Given this list of marker genes Zfp735, Calcoco1, Zcchc18, Vps29, Dcp2, Card10, Ppp1r9b, Eif2s2, B3glct, Rbm41, Ap3m1, Foxn3, Zfp426, Lbp, Ago1, Myo6, 9530002B09Rik, Bmerb1, Mdh1b, Zfp616, Rb1, Tac4, Klhl7, Syt4, Zdhhc6, Fndc3b, Ncam1, Sec61a1, Spef1, Ak5, Slc26a5, Camk2d, Nckap5, Btc, Synpo2 (NCBI Gene Id 99735), Vav1, Gja1, Trpm2, Gtdc1, Dppa1, Trps1, Rrh (retinal pigment epithelium derived rhodopsin homolog), Cyp2c54, Gpha2, Whamm, Dmkn, Shisa7, Pik3r3, Fign (fidgetin), here is a description of the gene set: from publication Chen Y, Wang X (PMID 31504780) species: Mus musculus Genes predicted to be targets of miRBase v22 microRNA mmu_miR_1224_5p in miRDB v6.0 with MirTarget v4 prediction scores > 80 (high confidence targets). Mouse Gene Set: MIR_1224_5P